Given this list of marker genes POLR2A, IMPA2, SPR, UBE2H, AKAP8, TNNI3, MAPK8IP3, PIAS3, ZNF358, EPS15, FIGNL1, CREB1, ULK1 (NCBI Gene Id 8408), HOXA6, SH2B1, AR, SART3, PDGFB, XRCC1, YLPM1 (NCBI Gene Id 56252), FBRS, IHH, WWC1, SETD6, NFIX, ABCC1, TRABD, FAM136A, ACTB, TAF1C, MICOS13, PCSK4, USP19, ACVR2B, EIF4EBP2, PRB1, NINJ1, TULP1, WDR45B, SNW1, CAND1, CUEDC1, IGKC, UBAP2L, APC, ROGDI, SFPQ, here is a description of the gene set: Cluster 3: genes activated by ionizing radiation regardless of ATM status. The ATM protein kinase, functionally missing in patients with the human genetic disorder ataxia-telangiectasia, is a master regulator of the cellular network induced by DNA double-strand breaks. The ATM gene is also frequently mutated in sporadic cancers of lymphoid origin. Here, we applied a functional genomics approach that combined gene expression profiling and computational promoter analysis to obtain global dissection of the transcriptional response to ionizing radiation in murine lymphoid tissue. Cluster analysis revealed a prominent pattern characterizing dozens of genes whose response to irradiation was Atm-dependent. Computational analysis identified significant enrichment of the binding site signatures of NF-kappaB and p53 among promoters of these genes, pointing to the major role of these two transcription factors in mediating the Atm-dependent transcriptional response in the irradiated lymphoid tissue. Examination of the response showed that pro- and antiapoptotic signals were simultaneously induced, with the proapoptotic pathway mediated by p53 targets, and the prosurvival pathway by NF-kappaB targets. These findings further elucidate the molecular network induced by IR, point to novel putative NF-kappaB targets, and suggest a mechanistic model for cellular balancing between pro- and antiapoptotic signals induced by IR in lymphoid tissues, which has implications for cancer management. The emerging model suggests that restoring the p53-mediated apoptotic arm while blocking the NF-kappaB-mediated prosurvival arm could effectively increase the radiosensitivity of lymphoid tumors. studied in species Mus musculus Human Gene Set: RASHI_RESPONSE_TO_IONIZING_RADIATION_3 from publication Rashi-Elkeles S, Elkon R, Weizman N, Linhart C, Amariglio N, Sternberg G, Rechavi G, Barzilai A, Shamir R, Shiloh Y (PMID 16314843)